The following is a description of a gene set: Mouse Gene Set: GOBP_LIPOPOLYSACCHARIDE_MEDIATED_SIGNALING_PATHWAY The series of molecular signals initiated by the binding of a lipopolysaccharide (LPS) to a receptor on the surface of a target cell, and ending with the regulation of a downstream cellular process, e.g. transcription. Lipopolysaccharides are major components of the outer membrane of Gram-negative bacteria, making them prime targets for recognition by the immune system. studied in species Mus musculus, and this is the list of marker genes: Acod1, Tut4, Prkca, Malt1, Mif, Myd88, Akt1, Trim12c, Cd14, Sash1, Scimp, Cx3cl1, Trim30c, Ripk2, Ptpn22, Mapk1, Sirpa, Irak2 (NCBI Gene Id 74787), Nr2c2, Defb21, Cd84, Prkce, Bpi, Cactin, Cd55, Irak3, Ptpn6, Trim5, Ly86, Traf6, Trim30d, Lbp, Stat1, Spi1, Plcg2, Ptpn11, Tlr4, Lyn, Mapk14, Irak4, Bcl10, Cd6, Tifab, Cd55b, Cd180, Trim12a (NCBI Gene Id 76681), Nfkbil1, Nos3, Prdx2, Trem2, Mapk3, Scarb1, Ltf (lactotransferrin), Irf3, Mtdh, Tnfaip3, Ptafr, Ticam1, Nfkbia, Trim30b, Irak1, Bmp6 (bone morphogenetic protein 6), Jak2, Trib1, Trim30a, Ly96